Given this list of marker genes CCER1, SEMA7A, SLC6A2, NPNT, PCOLCE, FEZF2, FBXO32, ZEB1, MYH2, UTP4, HOXD12, LINC00649, PAK1IP1 (NCBI Gene Id 55003), CSF2, IL10, ZNF646, ASIC1, MAML3, MGLL, HOXC11, GPM6A, FAM181B (NCBI Gene Id 283223), PIGV, ARID5A, NOL4, CAMK2A, MIER1, PURA, LINC00663, ADAMTSL2, ESM1 (NCBI Gene Id 11082), SEZ6, CREBZF, ALX4, MDGA1, PATE1, NFIL3, ZMYM4, OR8B8, MITF, LONRF3, TBX6, ARRB1, PPP1R1B, KDM6A, BANP, ARHGAP5, MSX2, HIC1, GPX1, DAAM1, NPVF, KCNH2, SYT6, FAM53B, WBP2NL, FAM180A, CDH13, AZIN1, HOXC4, WFDC3, ATP2A2, NR5A2, DLL4, GAP43, CTCF, XIRP1 (xin actin binding repeat containing 1), CRH, SYNCRIP, HOXD10 (NCBI Gene Id 3236), LRP2BP, NKAPD1, PHOX2B, MYH8, ESRRB, REST, MAP2, RAPGEFL1, FURIN, PIH1D2, ADARB2, UBE2K, SLC4A2, AQP2, PPP2R3A (protein phosphatase 2 regulatory subunit B''alpha), SGMS2, ELK3, NME7, DENND2B, SNAP25, SLC4A1AP, DIS3L, TAS2R40 (taste 2 receptor member 40), CNOT4, WT1-AS, ELOA2, FGF20, GABRA3, PTF1A, PPARA, LRRN3, NUDT4, COL11A2, ZNF423, ZNF668, PPIG, RASSF7, ZIC4, CERCAM, CSF3, ARMH4, SYTL2, ITGB3BP, LINC01597, TFAP2B, RTN4RL2, CCDC140, ST8SIA3, LMO3 (LIM domain only 3), GRID2, R3HDM2, DOLK, ATF3, MARCKS, ESRRG, ZBTB18, DNAI4, ITGBL1 (NCBI Gene Id 9358), GRIN2D, NR1D1, BLZF1, ZNF143 (NCBI Gene Id 7702), CDK5 (cyclin dependent kinase 5), FERD3L, DNTTIP1, TRPM3, TNFRSF19, FOXO3, SPATA7, CACNA2D3, FGF7 (fibroblast growth factor 7), PIWIL2, PAX3, KCNJ16, CGN, DUSP10, SLITRK1, NPFFR1, SEMA5B, HECTD2, WWC1, SIAH3, UNC13D, AP2B1, GPC4, USP3, SSBP3, PLEC, MYH4, MSI2, ZCCHC24, ZRANB1, ID3, SOX4, SF3B1, ELMO2, ZFPM2, GFPT2, PCF11, NCOR1, LMNTD2, PATL1, ISL1, DIP2B, RFX2, here is a description of the gene set: Comprehensive identification of all functional elements encoded in the human genome is a fundamental need in biomedical research. Here, we present a comparative analysis of the human, mouse, rat and dog genomes to create a systematic catalogue of common regulatory motifs in promoters and 3' untranslated regions (3' UTRs). The promoter analysis yields 174 candidate motifs, including most previously known transcription-factor binding sites and 105 new motifs. The 3'-UTR analysis yields 106 motifs likely to be involved in post-transcriptional regulation. Nearly one-half are associated with microRNAs (miRNAs), leading to the discovery of many new miRNA genes and their likely target genes. Our results suggest that previous estimates of the number of human miRNA genes were low, and that miRNAs regulate at least 20% of human genes. The overall results provide a systematic view of gene regulation in the human, which will be refined as additional mammalian genomes become available. from publication Xie X, Lu J, Kulbokas EJ, Golub TR, Mootha V, Lindblad-Toh K, Lander ES, Kellis M (PMID 15735639) Genes having at least one occurrence of the highly conserved motif M136 TAAYNRNNTCC in the regions spanning 4 kb centered on their transcription starting sites. The motif does not match any known transcription factor binding site. studied in species Homo sapiens Human Gene Set: TAAYNRNNTCC_UNKNOWN